Given this list of marker genes CANT1, ACVR1, BMPR1B, CNOT1, PCNT, IHH, MEG3, TRIO, SRCAP, PIK3CD, SALL4, VAC14, GNAS, KCNH1, TBX5, SF3B4 (splicing factor 3b subunit 4), RAD21, FANCD2, FGFR2, HOXA13, FANCI, DLK1, SOX9, PTCH1, SMC1A, FLNA, SETBP1, SMC3, KNSTRN, NOG, RTL1, LMBR1 (NCBI Gene Id 85501), MAP3K7, FZD2, SHH, VPS35L, ROBO1, LAMA5, GDF5, TAF6, ERI1, FIG4, BRD4, HDAC8, NIPBL, XRCC2, here is a description of the gene set: species: Homo sapiens Human Gene Set: HP_APLASIA_HYPOPLASIA_OF_THE_PHALANGES_OF_THE_THUMB Aplasia/Hypoplasia of the phalanges of the thumb